The following is a description of a gene set: Human Gene Set: GSE13484_UNSTIM_VS_12H_YF17D_VACCINE_STIM_PBMC_UP The immune responses generated by YF-17D by profiling genes in PBMCs from 2 donors cultured with YF-17D vaccine were accessed after 3 and 12 hours. species: Homo sapiens from publication Querec TD, Akondy RS, Lee EK, Cao W, Nakaya HI, Teuwen D, Pirani A, Gernert K, Deng J, Marzolf B, Kennedy K, Wu H, Bennouna S, Oluoch H, Miller J, Vencio RZ, Mulligan M, Aderem A, Ahmed R, Pulendran B (PMID 19029902) Genes up-regulated in comparison of unstimulated peripheral blood mononuclear cells (PBMC) cultured for 0 h versus PBMC cultured for 12 h with YF17D vaccine., and this is the list of marker genes: SECISBP2, CHP1, VPS9D1, LYZ (NCBI Gene Id 4069), PTP4A2, FASTK, PRKX, OSGEP, VPS53, ABCF3, PGLS, HERC3, ZC3H4, DERA, KRT9, AK2, TOE1, OLA1, IGF2-AS, SLC12A9, NGDN, ATP1A1, TPM1, ZDHHC7, DDX47, TKT, EIF2B3, ANK1, NDC1, SRSF5, CNOT7, RPS6KB1, CDIPT, EEF1D, PLEKHA6, PMM1, FHOD1, PYCARD, LIME1 (NCBI Gene Id 54923), CD27, BTAF1, ADA2, PIGB, UQCRC2, RPSA, FBP1, FXR1, DNAJC9, RPS11, PEPD, URI1, HSPA14, COLGALT1, TUBGCP2, ZBTB14, HOMER2 (NCBI Gene Id 9455), NELFCD, STN1, DLEC1 (DLEC1 cilia and flagella associated protein), MPO, C2CD2, AUH, GLMN, ATP5IF1, SEC24C, H2AC4, SUPT7L, FKBP6, GABRA2, ZFAND3, ATP5ME, EEF1G, NPEPL1, VAMP8, RXRA, AKAP1, MTRF1, MAN1A1, ZMYND11, RASSF2, PECAM1, MORN1, NUCKS1, LZTFL1, PTGS1, NAIP, FBL, ELAVL1, HOXA9, MEF2C, SRSF6, PDS5A, HLA-DPB1, ANKRD26, RANGRF (RAN guanine nucleotide release factor), PCSK7, DENND1C, MATR3, PPP6R3 (protein phosphatase 6 regulatory subunit 3), P3H1, AATF (apoptosis antagonizing transcription factor), NDUFS7, TBKBP1, ARGLU1, CTNNBIP1, NR4A2, EID1, TMEM134, POLQ, SCPEP1, DDX42, AQR, SLC25A36, CD248, HPS1, GRM8 (NCBI Gene Id 2918), EIF3G, IQSEC1, RPL10L, CDK13, HRH3, VAMP2, RPS25, RHOBTB1, MAP7D3, PSTPIP1, INPP4B, TPD52, DYM, QRICH1, SLC2A4RG, IFFO1, CAVIN2, IGF2BP3, VPS51, OAT, CAT, POLR2H, SLA, ZNF34, RPS24, DGKA, SRRM1, EHD3, TNFSF13, PHTF2, ARL4C, YBX3, DPP6, ALDH3A2, BLCAP, TRIB2, CRTAP, PROSER1, PDHA1, YTHDC2, CASP8AP2, PGRMC1, TAL1, CORO1A, SMIM7, RERE, CD36, TPP1, CITED2, NOP53, SPTBN2, LARP1, ABLIM3, FLI1 (Fli-1 proto-oncogene, ETS transcription factor), SMAD1, IARS2, PARD3 (par-3 family cell polarity regulator), MTMR4, CTDSPL, CBFA2T3, XPNPEP1, BACE2, GLRA3, IL11RA, PRKACA, HSD17B4, MIEF1, MINDY1, GARNL3, TSPAN8, SORL1, VAMP1, CDK2AP1, ORC4, DNAJC16, AKAP9, AXIN1, ITPK1, MRPS2, NINJ2, BABAM1, UFC1, RCN1